Given this list of marker genes NIPAL4, ZNF341, HLA-DPA1, NDUFA6, ATP6V0A2, GAS8 (growth arrest specific 8), PWAR1, LAMA2 (laminin subunit alpha 2), STXBP2, RNF125, RAG2, TRIM8, LIMK1, TRAIP, MIF, ADAMTS3, RAP1B, CRKL, TBX20, EXOSC9, MEGF10, LAMTOR2, PCGF2, CCDC40, IL10RB, WAC, COL6A1, ADNP, CD27, CLEC7A, TBC1D24, PEX13, TLL1, HLA-B, ITCH, HLA-DRB1, NODAL, CD3D, SNX10, KANSL1, SLC46A1, BAZ1B, MALT1, ARSL, VPS37D, METTL27, PLCE1, KATNIP, AASS, COL4A5, PTCH1, NECTIN1, ARHGEF1, NSD2, KCNN4, PAK2, TYMS, ITGA3, CORO1A, MTHFD1, LRIF1, TTC7A, SLC1A4, DZIP1L, GFI1, CTBP1, SLC35C1, EIF4H, DSG1, AGA, LAT, VPS35L, PCNT, GRM7, PIK3CG, DNAAF5, CLIP2, ATP6V0A1, CDKL5 (NCBI Gene Id 6792), ADA, FOXP2, PTPN22, HACD1, TRPC6, HYOU1, EFEMP2, MBTPS2, CCDC22, SOX4, LCK, MCM4, GSTM3, PLCH1, TRIP4, LAMC2, RFX7, CPLX1, SMC1A, GRIA1, NUP37, GLI3, FBXO11, OAS1, FGF8, DPP9, POLA1, KAT6B, MYL9, IL17RC, AGRN, BCL10 (NCBI Gene Id 8915), CLXN, ELF4, NCF1, CEBPE, ICOS, NFKBIA, GEMIN4, COL6A2, MAN2B1 (NCBI Gene Id 4125), COG4, IFNG, SNORD115-1, RELB, MARS2 (methionyl-tRNA synthetase 2, mitochondrial), SLC6A14, DAW1, ROR2, MYPN, RNF113A, ORC6, AFF4, CD3E, GTF2H5, TNFRSF13C, FOXN1, NUP85, SLC34A2, TFG, MGP, SCN9A, KMT2D, NAE1, WRAP53, CFAP298, SPAG1 (sperm associated antigen 1), DRC1, ZNF668, PLP1, MAP3K20, CSF2RB, RNF168, PLEC, PURA, MIR140, CD19, EDA, TET2, NEUROD2, CASP8, PSMB8, WASHC5, POLD3, TRAF3IP1, ECM1, IL21, COL5A1, TASP1, NUP214, H4C5, CARD10, NPAP1, LRBA, TNFSF11, TNNT2, AK2 (NCBI Gene Id 83165), FBXO28, AP3B1, UNC119, PLOD1, SRP19 (NCBI Gene Id 6728), SHH, MYH6, GNS, TERC, KCNJ6, PAX2, CRIPTO, STIL, MDM4, HERC2, TGIF1, ZNHIT3, FOCAD, RMRP, SNAP25, PRPS1, ODAD4, NOTCH2NLC, RAI1 (retinoic acid induced 1), CD40LG, DNAL1, IRAK4, C1QB, CD4, TSC1, UGP2, UBB, CFTR, CLPB, STAT6, TRIM37, NHLRC1, BCR, PEX5, DEPDC5 (NCBI Gene Id 9681), CFAP300, ANKFY1, ODAD3, KDM5C, PIK3CD, MPLKIP, ARPC5, CDCA7, SLC29A3, IER3IP1, GBA1, IL2RG, ACTA1, IL12RB1, BMP4 (NCBI Gene Id 652), MDFIC, C3, SLC35A1, SCNN1A, WAS, ATP6V1B2, CTPS1, SLC37A4, DEAF1, BUD23, STIM1, PARN, CR2, LIG1, JAGN1, CIITA, DYM, PLG, MYO9A, PSMB9, ZMYND10, WDR19, ICOSLG, ERCC3, UMPS, GTF2IRD1, NUP107, EGFR, INF2, FLI1, RAB3GAP2, CD79A, TAOK1, HGSNAT, FBLN5 (fibulin 5), EMP2, ACP5, CARD11, IDS, UQCRH, NME5 (NCBI Gene Id 8382), MYSM1, TBC1D8B, SDCCAG8, FAT4, MCIDAS, ERF, MAGT1, DNAJB13, CHAT, USP26 (ubiquitin specific peptidase 26), CARS1, SP110, TNFRSF9 (TNF receptor superfamily member 9), POLD1, INPPL1, LAMA3, CYBA, IL17RA, ERCC2, CBLB, TRIP11, SIX3, CFI (NCBI Gene Id 3426), CD3G, PIK3R1, ASXL1, RFT1, BRWD1, IRF8, JAK3, NEPRO, PLA2G6, DNAAF6, FCHO1, SH3KBP1, MAGI2, PRTN3, NOP10, SNAP29, HK1, SLC39A7, MECP2 (methyl-CpG binding protein 2), NUP133, CFB, DOCK11, DYNC2I2, UBAP2L, TNFSF12, ATM, NRAS, CHRM3, DLL3, RFXANK, IDUA, TFRC, CTCF, B2M, LIPN, CEACAM6, PLCG2, FCN3, DDX59, CTC1, DNAI1, MYL2, SCNN1G, TBK1, CREBBP, NTRK1, CD81, GATA6, GATA4, PGM3, IL2RB, WDR1, GIPC1, IFNGR1, DAAM2, SMARCA4, FOXJ1, KIF20A, SCN10A, CD247, STAT3, COQ8B, ASPRV1, TMEM270 (transmembrane protein 270), KPTN, PSMD12, VARS1 (valyl-tRNA synthetase 1), ITGA7, UBA2, ZNFX1, LAMB3, KNSTRN, ELP1, NDN, CTSC, DISP1, NELFA, NUP160, ALB (NCBI Gene Id 29004), ABCA3, NFKB1, SH2D1A, BIRC3, TONSL, ALOX12B, FGFR1, STK4, TERT, DNAJC21 (NCBI Gene Id 134218), MAGEL2, RNH1, SAMD9, CYBC1, DCLRE1C, FCSK, SMARCE1, IFT140, IDH1, SGCG, NFIX, WT1 (NCBI Gene Id 7490), RAC1, PET117, ARPC1B, PTCD3, USP9X, GLUL, ELANE, TBL2 (transducin beta like 2), NGLY1 (NCBI Gene Id 95041), CRLF1, COL5A2, PYROXD1, CFAP74, IKBKB, TOM1, GTF2IRD2, TNFRSF13B, HFE (NCBI Gene Id 3077, homeostatic iron regulator), LONP1, GNAO1, UNG, TK2, RANBP2 (RAN binding protein 2), IVNS1ABP, TPP2, CEACAM3, FCGR3B, AP3D1, TREX1, COLQ, WIPF1, PLVAP, NPM1, FUCA1, HELLS, CD79B, PHIP, CD8A, DNAH5, LEP, PIGQ, ARHGDIA, MYO1E, GSN, SPI1, FANCF (FA complementation group F), G6PC3, ARX, PNP, PRKDC, NCF2, FCGR3A, NXN, KAT6A, RILPL1, EHMT1, GCLC, IL2RA, DNAH1, TAPBP, SLC32A1, LTBP1, ALPL, PSAP, DNAH9, RPGR, IGHG2, TNFRSF11A, IFT122, DOCK2, RSPH3, OSTM1, PIGG, FIG4, KRT5, NADK2, CITED2, VPS33A, SELENON, RFXAP, DPF2, PTPRO, LMNB1, NFKB2, ALOXE3, CFAP410, DIP2B, FLII, CSPP1, MYO1H, STING1, PKHD1, OCRL, RAG1, HLA-DPB1, MANBA, SGSH, IL17F, TMCO1, CFAP221, ZAP70, CACNA1B, NKX2-5, SYK, GTF2I, ODAD2, SYT2, TNFRSF1A, RYR1, DNAH7, ARID1B, SMN1, RSPH1, DPM2 (NCBI Gene Id 8818), IL7R, ZBTB24, FKBP6, AARS1, GLB1, SLC25A22, ASAH1, TRAF3IP2, FCGR2A, CARMIL2, DNAAF3, CYP4F22, PPP1R21, ZNF699, MYO5A, RNU4-2, MYH3, SHROOM4, PIGA, SCN1B, CHAMP1, POLE, C4B, RTEL1, DNAI2, HYDIN, CLCA4, IRF1, IL21R, MID1, LAMB2, FBXW7, GTF2E2, SCNN1B, TCEAL1, GFM2, SCN11A, TBX1, APOL1, SIM1, ELN, SOX11, TINF2, ARSB, CAVIN1, SFTPC, COL11A2, TARS1, GAA, ALG12, USB1 (NCBI Gene Id 79650), SPTBN4, RASGRP1, CDON (cell adhesion associated, oncogene regulated), GLI2, TCIRG1, VAMP1, SLC26A9, LRRC56 (leucine rich repeat containing 56), SAMD9L, MYOD1, STK36, SLC25A1, ARID2, NDUFC2, TP73, CLCN7, BACH2, KRAS, ERCC6, FOXP3, IGHM, IQSEC2 (NCBI Gene Id 4382), SMARCD1, GNPTAB, TNNI3, FMO3, POLR3A, IGLL1, NME8, P4HTM, DNAAF2, NKX2-1, ZIC2, TBCD, WDR35 (NCBI Gene Id 57539), SPINK5, GRHL3, SREBF1, TIMM8A, COL4A6, FLNC, LEPR, PIGP, MGAT2, TIMMDC1, IGBP1, HLA-DQA1, MED25, PMM2, TRPS1, ANLN, NPHS2, DPYSL5, CYBB, TYK2, TAFAZZIN, IL6ST, DNAH11, TRAC, DLL1, GMNN, HLA-DQB1, COL13A1, LTBP4, HMOX1, HPS6, NHP2, SULT2B1, STAT1, POGZ, BTK, TAF1, RAC2, TSC2, GATA2 (GATA binding protein 2), ACBD6, GAS2L2, IKBKG, NEK10, ALDH18A1, DNAAF4, SETBP1, NEU1 (neuraminidase 1), ARHGAP24, SMARCC2, ACTN4, CXCR4, P4HA2, TTC12, LRRC8A, SERPINH1, DNAAF1, DKC1, EDNRA, SMARCD2, RFX5, SLC26A2, MKRN3, RSPH9, AICDA, ODAD1, ADA2, MSN, SERPINA1, CTLA4, PIGN, CCNO, PNKP, PTEN, RNU4ATAC, IL6R, EXTL3, STAG2, EFL1, PANK2, GAS1, SMARCB1, ALMS1, MAPK1, NIPBL (NIPBL cohesin loading factor), CD55, CHD7, RIPK1, FOXP1, FUT8, CASK, TECPR2 (NCBI Gene Id 9895), SFTPB, SNRPN, NCF4, SNORD116-1, DMXL2, TMEM94, MESP2, EPM2A, SMPD1, B3GALT6, DCTN4, LRP12, NOTCH2, CSF2RA, LIG4, TBX6, SMARCA2, PRKCD, RFC2, SCN2A, DOCK8, KCNA1, COL4A3, SLC12A6, SOX9, LYST, NHLRC2 (NHL repeat containing 2), BLM, MASP2, NFASC, OCA2, NUP205, EPG5, SOCS1, PKP1, SLC4A10, RUNX2, RAPSN, SLC25A24, REL, TBCE, SLC19A1, NOS1, UHRF1, ACTC1, LTBP3, CCDC103, CCDC39 (NCBI Gene Id 339829), TAP2, GAPVD1, HCK, EDARADD, KIAA0586, SIAH1, DNAAF11, CRB2, OFD1, TPM3, ABCA12, AGR2, CTNNBL1, EP300, NUP93, NPHS1, TCTN3, PDHA1, RSPH4A, TCF3, DNMT3B, ZBTB7A, ACADVL, SLC5A7, UFC1 (NCBI Gene Id 51506), TGM1, TGFB1, UBE2A, IFIH1, DNAJC30, TBC1D23, IRF2BP2, SPEF2 (NCBI Gene Id 80192), DDR2, IKZF1, SLC41A1, CCBE1, XIAP, SLC18A3, NFE2L2, GRIN1, STX1A (syntaxin 1A), SDHD, VPS51, SLC52A3 (NCBI Gene Id 113278), PEPD, PAFAH1B1 (platelet activating factor acetylhydrolase 1b regulatory subunit 1), MRAP, SLC9A3, ARID1A, BLNK, POLR2A, STX3, H4C3, REEP1, MAP3K14, GALNS, FLNA, COG6, CD2AP, SLC11A1, SDR9C7, TAP1, FOXH1, SASH3, IFT56, NAGLU, TPM2, GORAB, CCDC65 (coiled-coil domain containing 65), SUCLG1, SEC61A1, SATB1, MS4A1, CACNA1C, LETM1, PWRN1, MTM1, KDM6A, NBN, SIK1 (NCBI Gene Id 54018), GUSB, IGKC, SBDS, here is a description of the gene set: An infection of the upper or lower respiratory tract. Respiratory tract infection Human Gene Set: HP_RESPIRATORY_TRACT_INFECTION studied in species Homo sapiens